Given this list of marker genes HOXB9, HLTF, SMC1A, SNAP25, SECISBP2L, FEZ2, DCX, MED26, HOXA4, CS, MSTN, SLC39A10, PTPN9, PAPPA (NCBI Gene Id 5069), RBM3 (RNA binding motif protein 3), TMEM117 (transmembrane protein 117), ARIH1, METTL5, RND3, KCND2, PKNOX1 (NCBI Gene Id 5316), PLEKHA3, BRINP3, HMGN3, MAGED1, ILF3, ING3, CELF2, ISL1, CBX8, FST, SCRT1, BCL2L2, CUL3, PABIR1, GTF3C4, AEBP2, TP53INP2, RNF40, FBRS, TNPO2, LYSMD1, YPEL1, ARGLU1, TWIST1, HOXB13, here is a description of the gene set: studied in species Homo sapiens Genes having at least one occurence of the motif TCTAGAG in their 3' untranslated region. The motif represents putative target (that is, seed match) of human mature miRNA hsa-miR-517* (v7.1 miRBase). Human Gene Set: TCTAGAG_MIR517